The following is a description of a gene set: species: Mus musculus Mouse Gene Set: GOBP_REGULATION_OF_SMAD_PROTEIN_SIGNAL_TRANSDUCTION Any process that modulates the rate, frequency or extent of SMAD protein signal transduction., and this is the list of marker genes: Xbp1, Lgals9, Bmp7, Atoh8, Pmepa1, Dkk1, Ski, Grem1, Smad4, Bmp5, Tob1 (NCBI Gene Id 22057), Parp1, Gdf15, Bmper, Pparg, Inhba, Bmpr2, Eid2, Tgfb2, Mir7-1, Acvr2a, Eng, Mir130a, Acvrl1, Mir181c, Gdf11, Mir290a, Glce, Nup93, Mir181d, D130043K22Rik, Pin1rt1, Gdf2, Bmp2, Tbx20, Gdf7, Mir382, Veph1, Jak2, Smad6, Gdf5, Csnk2b, Tgfbr3, Pin1, Bmpr1a, Bmp4, Sh2b1, Mir7-2, Bmp10, Tgfb3 (NCBI Gene Id 21809), Smad7, Tgfbr1, Nodal, Ucma, Gdf6, Mir25, Lrp1, Ldlrad4, Tgfb1, Emilin1, Mir744, Nog, Cilp, Twsg1, Hfe, Mir185, Tgfbr2, Bmp6, Smad3, Ovol2, Dab2, Amh, Sptbn1, Fam89b, Ccn3, Acvr1